Given this list of marker genes HES5, TREX1, ANKLE1, NOTCH1, SHH, SOX4, SPI1, PCID2, ZBTB1, ZNHIT1, FLT3, NUDT21, FNIP1 (folliculin interacting protein 1), LIG4 (NCBI Gene Id 3981), PRKDC, HES1, SOS2, SOS1, GATA3, FLCN, BMP4, BATF, KIT, BCL2, here is a description of the gene set: Human Gene Set: GOBP_LYMPHOID_PROGENITOR_CELL_DIFFERENTIATION studied in species Homo sapiens The process in which a precursor cell type acquires the specialized features of a lymphoid progenitor cell. Lymphoid progenitor cells include progenitor cells for any of the lymphoid lineages.